The following is a description of a gene set: The process aimed at the progression of a mesenchymal cell over time, from initial commitment of the cell to its specific fate, to the fully functional differentiated cell. species: Homo sapiens Human Gene Set: GOBP_MESENCHYMAL_CELL_DEVELOPMENT, and this is the list of marker genes: NOTCH1, FOXC1, TBX20, HEY2, HEYL, BCL2, ALX1